Given this list of marker genes PNPLA6, KLHL41, NEB, PNPLA2, KBTBD13, SPG11, ACTA1, SCO2, TPM3, YARS2, MEGF10, CARS1, DARS2, TPM2, SCYL1, SGCD, MYPN, PUS1, GMPPB, MYH7, here is a description of the gene set: Human Gene Set: HP_GENERALIZED_LIMB_MUSCLE_ATROPHY studied in species Homo sapiens Generalized (unlocalized) atrophy affecting muscles of the limbs in both proximal and distal locations. Generalized limb muscle atrophy